The following is a description of a gene set: Human Gene Set: GOBP_DEDIFFERENTIATION The process in which a specialized structure (cell, tissue or organ) loses structural or functional features that characterize it in the mature organism, or some other relatively stable phase of the organism's life history. Under certain conditions, these structures can revert back to the features of their ancestors. studied in species Homo sapiens, and this is the list of marker genes: FEZF1, MIR182, FEZF2, CDK6, MIR145, MIR214, NCOA3, OLFM2, PDGFB, MIR221, HNRNPD, ESRRB